Given this list of marker genes CHCHD10, IMMT, CHCHD6, APOO, MICOS13, DNAJC11, MICOS10, CHCHD3, APOOL, here is a description of the gene set: species: Homo sapiens Human Gene Set: GOCC_MICOS_COMPLEX Mitochondrial inner membrane complex involved in maintenance of crista junctions, inner membrane architecture, and formation of contact sites to the outer membrane. In Saccharomyces cerevisiae the complex has six subunits: MIC10, MIC12, MIC19, MIC26, MIC27, and MIC60.